The following is a description of a gene set: part of: Toll-like Receptor Cascades electronically inferred by orthology from the curated human pathway species: Mus musculus This event has been computationally inferred from an event that has been demonstrated in another species.<p>The inference is based on the homology mapping from PANTHER. Briefly, reactions for which all involved PhysicalEntities (in input, output and catalyst) have a mapped orthologue/paralogue (for complexes at least 75% of components must have a mapping) are inferred to the other species. Reactome Pathway: Toll Like Receptor 7/8 (TLR7/8) Cascade, and this is the list of marker genes: Rps6ka5, Nlrc5, Ube2n, Nkiras1, Ly96 (NCBI Gene Id 17087), Map2k4, Mapk11, Ticam2, Ppp2r1b, Ikbkb, Mapk7, Dusp7, Irf7, Ager, S100b, Tlr4, Irak1 (NCBI Gene Id 16179), Nlrx1, Casp8, Rps27a, Ube2v1 (NCBI Gene Id 66589), Tifa, Map3k8, Lrrc14, Mapk3, Jun, Cd14, Nfkbia, Nfkb1, Rela, Tasl, Tab1, Mapk14, Map2k7, Ppp2r5d, Fos, Nfkbib, Cul1, Hmgb1, Mapk8, Ubb, Dusp6, Map2k3, Nfkb2, Tlr7, Vrk3, Peli2, Tab2, Tab3, Ecsit, Irf5, Mapk9, Map2k6